Given this list of marker genes Commd1, Washc1, Lamtor1, Stard4, Lrp1, Scarb1 (NCBI Gene Id 52288), Apoc3, Ldlr, Stard5, Adipoq (adiponectin, C1Q and collagen domain containing), Apoa2, Apoa1, Scp2, Cd36, Npc1l1 (NCBI Gene Id 278378), here is a description of the gene set: The directed movement of cholesterol into a cell or organelle. Mouse Gene Set: GOBP_CHOLESTEROL_IMPORT studied in species Mus musculus